The following is a description of a gene set: species: Homo sapiens from publication Eisenbarth SC, Williams A, Colegio OR, Meng H, Strowig T, Rongvaux A, Henao-Mejia J, Thaiss CA, Joly S, Gonzalez DG, Xu L, Zenewicz LA, Haberman AM, Elinav E, Kleinstein SH, Sutterwala FS, Flavell RA (PMID 22538615) Nlrp10-deficient mice have a profound defect in helper T cell-driven immune responses. T cell priming is impaired due to a defect in the emigration of a dendritic cells from inflamed tissue and antigen transport to draining lymph nodes. DC chemotaxis to CCR7-dependent and independent ligands is intact in the absence of Nlrp10. Therefore to identify novel molecules potentially involved in Nlrp10-dependent DC function we used an unbiased gene array approach on Nlrp10-deficient BMDCs treated with or without LPS. Human Gene Set: GSE36009_UNSTIM_VS_LPS_STIM_DC_DN Genes down-regulated in dendritic cells: control versus LPS., and this is the list of marker genes: SWAP70, CLN5, CPD, DYRK1A, OGT, ENTR1, CERK, IFT57, KATNBL1, ATXN7L3B, DNAJB1, TAB2, LMO4, TRAPPC10, PPP1R12B, EXTL2, PAIP2, SMAD2, MAML1, CLEC4D, CTDSP2, KPNA1, RPS19BP1, ZNF574, TAF2, SLC38A2, UBXN7, NFKB2, POLR2M, ACP2, EHBP1L1, TGFBR1, ACBD3, PKNOX1, POLR2D, HIVEP3, AKNA, ZNF24, PRKAB2, PIK3CA, FAM76A, TMBIM1, UTP4, MLLT6, STX5, CNBP, MICOS10, TTC32, SLC7A6, HCLS1, PHAF1, MEX3D, THAP11, CLPX, TRMT5, PEX10, ADO (NCBI Gene Id 84890), LRRC75A, RBL2, C1GALT1, TMCC1, ARHGAP30, MAP7D1, NIFK, TSC22D4, TUSC2, ZFYVE1 (zinc finger FYVE-type containing 1), ETF1, ZNF274, PPP1R21, ABCC1, TOB1, STX6, ARMC7, TRMT2A, TOLLIP, STMP1 (NCBI Gene Id 649778), RNF2, EGR2, GPR85, CAPN15, HMGB3, PIK3CG, LENG1, MEPCE, ARHGEF7, METTL14, EYA3 (EYA transcriptional coactivator and phosphatase 3), CD44, MIEF1, TOP1, ABRAXAS2, RSF1, TXNRD1, ZSWIM4, SH3TC1, MTMR10, TMEM199, ARFGAP3, PNN, HYAL2, SPRING1, ATP6V1C1, ZNF229, SERPINB8, CD28, WDR81 (NCBI Gene Id 780925), LUC7L, C5orf34, CHCHD4, JADE2, DCAF10, SLBP, TRIM33, RNF113A, DLST, LYRM2, KMT2E, HBP1, FOXN2 (NCBI Gene Id 3344), CCSAP, ZNF383, GALNT6, BAHD1, FRMD6, ZMYM2, UBE2E3 (NCBI Gene Id 10477), STK40, GRAMD1A (NCBI Gene Id 57655), TBC1D20, PRELID3B, MTA2, SRXN1, ARFGAP2, MEMO1, GPCPD1, PPP4R2, MAFG, RHOG, RNMT, GPR65, SDHAF1, TTC19, MAD2L1BP, FAM210A, ST3GAL5, ATOSA, ATXN2, CYTH3, SENP2, DUSP3, CDK20, NCBP3, RABIF, RARG, RCSD1, ATP6V0A1, PMP22, SEC14L1, ZBTB11, CEP57, CCDC115, SLC25A51, STK17B, CTNS, KLF16, LIG3, JDP2, ZBTB42, FBXO28, RASSF8, ULK1, B3GNT8, TMEM263, RBM5, THUMPD1, CACUL1, SUPT20H (NCBI Gene Id 55578), SH3BP4, SAMTOR, TMEM119, GIT2, ARRDC2, ATG16L2, NOPCHAP1, ANP32B (NCBI Gene Id 138551), MED20, BLCAP, PPP2R2D, TSPAN14, PHRF1, MEX3C, EEPD1, ZNF639, TUBA4A, MID1IP1, PPP2R1B, MON2, TERF1, RELB